Given this list of marker genes GSR, GSTA5, GSTA1, GPX4, GGT1, IDH1, GSS, GGT5, GSTM1, GPX2, ANPEP, OPLAH, GPX1, GCLM, GSTT2, G6PD, GCLC, GSTM2, GPX3, here is a description of the gene set: Human Gene Set: WP_GLUTATHIONE_METABOLISM studied in species Homo sapiens Glutathione metabolism